The following is a description of a gene set: Human Gene Set: HILLION_HMGA1_TARGETS from publication Hillion J, Dhara S, Sumter TF, Mukherjee M, Di Cello F, Belton A, Turkson J, Jaganathan S, Cheng L, Ye Z, Jove R, Aplan P, Lin YW, Wertzler K, Reeves R, Elbahlouh O, Kowalski J, Bhattacharya R, Resar LM (PMID 19074878) studied in species Rattus norvegicus Although HMGA1 (high-mobility group A1; formerly HMG-I/Y) is an oncogene that is widely overexpressed in aggressive cancers, the molecular mechanisms underlying transformation by HMGA1 are only beginning to emerge. HMGA1 encodes the HMGA1a and HMGA1b protein isoforms, which function in regulating gene expression. To determine how HMGA1 leads to neoplastic transformation, we looked for genes regulated by HMGA1 using gene expression profile analysis. Here, we show that the STAT3 gene, which encodes the signaling molecule signal transducer and activator of transcription 3 (STAT3), is a critical downstream target of HMGA1a. STAT3 mRNA and protein are up-regulated in fibroblasts overexpressing HMGA1a and activated STAT3 recapitulates the transforming activity of HMGA1a in fibroblasts. HMGA1a also binds directly to a conserved region of the STAT3 promoter in vivo in human leukemia cells by chromatin immunoprecipitation and activates transcription of the STAT3 promoter in transfection experiments. To determine if this pathway contributes to HMGA1-mediated transformation, we investigated STAT3 expression in our HMGA1a transgenic mice, all of which developed aggressive lymphoid malignancy. STAT3 expression was increased in the leukemia cells from our transgenics but not in control cells. Blocking STAT3 function induced apoptosis in the transgenic leukemia cells but not in controls. In primary human leukemia samples, there was a positive correlation between HMGA1a and STAT3 mRNA. Moreover, blocking STAT3 function in human leukemia or lymphoma cells led to decreased cellular motility and foci formation. Our results show that the HMGA1a-STAT3 axis is a potential Achilles heel that could be exploited therapeutically in hematopoietic and other malignancies overexpressing HMGA1a. Genes changed in Rat1a cells (fibroblasts) by overexpression of HMGA1 isoform a off a plasmid vector., and this is the list of marker genes: PSMA1, RPL36A, INSR, ESR2, AKR1A1, CD3G, ARAF (NCBI Gene Id 369), ERBB2, CFL1, PSMB6 (NCBI Gene Id 95505), PNLIP (NCBI Gene Id 5406), PCNA, TFRC, SLC25A5, CXCL6, MIF, STAT3, GPR6, MYCN (NCBI Gene Id 53360), RPS3A (NCBI Gene Id 6189), PMP22 (NCBI Gene Id 5376), RPL13, NGF, PLCD4, MOS, IGF2R, RPL21, MGST1, B2M, P2RX1, ATP5MC1 (ATP synthase membrane subunit c locus 1), GPX3, C5AR1, ACHE (acetylcholinesterase (Yt blood group)), CTSV, VCP, CHRNB1, RPS11 (ribosomal protein S11), HSPD1, SLC6A11, IRS1, LIMK1, EEF2, CLU, TK1, GHR, GABRR1, TAC1, COX5A (cytochrome c oxidase subunit 5A), NPY, CXCR4, RPS17, GRM1, CRIP2, ID2, DCC, HSPB1, RPS12, ATP5PB, ID1, ALDOA, EDNRB, SOD1, HTR6, COX4I1, ID3, HSP90AB1, GLRA1, MAK, TACR1, NEO1, COX5B, CXCL2, NME1, RPL19, GMFB, TGFB3, GABRB1, HRAS, NME2, AKT1 (AKT serine/threonine kinase 1), ATP5MC2